The following is a description of a gene set: species: Mus musculus Genes up-regulated in MEF cells (embryonic fibroblasts) after knockout of PML and whose promoters were bound by MYC. Mouse Gene Set: CAIRO_PML_TARGETS_BOUND_BY_MYC_UP c-myc is a well-known proto-oncogene encoding for a transcription factor that needs to be tightly regulated in order to preserve cell homeostasis. The Promyelocytic Leukaemia gene product PML plays an important role in cell growth and survival, and resides in discrete subnuclear structures called Nuclear Bodies (NB). We performed comparative analysis of the expression of 40 Myc target genes and of Myc binding to their regulatory regions both in wild-type and PML knockout cells. We demonstrate that if PML is absent, despite Myc binding to the DNA regulatory sequences is unchanged, the expression profile of several Myc target genes is altered. PML is largely involved in gene regulation, via recruitment of several transcription factors and cofactors to the NB. Consistently, we show that Myc partially localizes to the NB and physically interacts with PML, and that this localization depends on Myc expression levels. As deregulation occurs to both activated and repressed Myc target genes, we propose that PML influences Myc transcriptional activity through a mechanism that involves the control of Myc post-translational modifications. from publication Cairo S, De Falco F, Pizzo M, Salomoni P, Pandolfi PP, Meroni G (PMID 15735755), and this is the list of marker genes: Cdk4, Thbs1, Cdca7, Bcat1 (branched chain aminotransferase 1, cytosolic), Ccnd2, Dnph1, Ybx1, Cul1, Tk1, Npm1 (NCBI Gene Id 18148), Cad, Id2, Eif2a, Ddx18, Eif4e, Ldha, Trp53, Ptma, Polr3d, Bax, Ccnb1, Cdc25a